Given this list of marker genes Il2, Dnajc12 (NCBI Gene Id 30045), Zfp592, C1galt1c1, D630045J12Rik, Sptlc2, Upf1, Cript, Sec63, Zfp280d, Reps2, Potefam3b, Magt1, Crkl, Zfp799, Zbtb37, Tram1, Aqp4, Eya1, Caps2, Zbtb39, Bbs7, Rgmb, Rnf157, Chmp5, Nectin3, Phip, Ptp4a2, Vcf1, B4galt7 (NCBI Gene Id 218271), Phf20l1, Vcan, Ednrb, Hebp1, Zfx, Hcrtr2, Med15, Map3k2, Ocrl, Capza1, Asb15, Aifm1, Mrgprd, Hif1a, Erlec1, Paip2b, Grm7, Notch1, Rab27b, Fst, Zfp758, Zfc3h1, Ciao2a, Hbb-bh1, Cdh11, Brpf1, Scn9a, Scai, Lztfl1, Fam149a, Atm, Potefam3e, Efna5, Zic1, Mzt1, Kif1b, Hook2, Map4, Ndrg1, Sema3d, Zfp961, Mgst1, Brinp2, Abhd17c, Ankrd17, Myo6, Snx10, Ubqln2, Ube2r2, Ogt, Ebf2, Tpbg, Atp11c, Garnl3, Ube4a, Hdac4, Col15a1, Lrp2bp, Nfat5, Lefty2, Cxxc5, Lrp11, Heph, Potefam3a, Hipk4, Htr2c, Fhip2a, Gria2, Bzw1, Lox, Arid3c, Man1a2, Gzf1, here is a description of the gene set: species: Mus musculus Mouse Gene Set: MIR_216C_5P Genes predicted to be targets of miRBase v22 microRNA mmu_miR_216c_5p in miRDB v6.0 with MirTarget v4 prediction scores > 80 (high confidence targets). from publication Chen Y, Wang X (PMID 31504780)